Given this list of marker genes FEZ2, TSC22D4, SDCBP, STX4, NOVA1, TSHZ2, KARS1P1, OR1X5P (NCBI Gene Id 403233), CWC25, NOVA1-DT, ZNF827, RPL15P15, PCGF3, DVL2, FCHO2, BRWD1, SNHG30, FABP5P3, RNA5SP230, RAB11FIP5 (NCBI Gene Id 26056), RNU6-859P, HAPLN2, DAGLB, ETV4, NDUFA6-DT, NOL6, NR2F1-AS1, WNT8A, ADA, LBX1-AS1, SYF2P2, RND1, GALNTL5, USF1P1, CMKLR2-AS, CICP12, SDC4, NAPSA, ABHD17A, TRIM15, RASA4EP, EVA1C, GAPDHP66, HNRNPMP2, SRFBP1, ITGAL-AS1, RRN3P1, IGSF21, NCKAP1L, GBA1, CYP1B1-AS1, MED21, CYP2D6, MTO1, SAXO3, PRDM6, CROCCP3, FES, STX17, TTC1, GIT2, HEBP2 (NCBI Gene Id 23593), RN7SL680P, FOXP2, COX6CP3, CCN1, DAZAP1, STAT6, here is a description of the gene set: Genes containing one or more binding sites for (ZNF791) in their promoter regions (TSS -1000,+100 bp) as identified by GTRD version 20.06 ChIP-seq harmonization. Human Gene Set: ZNF791_TARGET_GENES from publication Yevshin I, Sharipov R, Kolmykov S, Kondrakhin Y, Kolpakov F (PMID 30445619) studied in species Homo sapiens